The following is a description of a gene set: Human Gene Set: GOBP_INTRACILIARY_ANTEROGRADE_TRANSPORT studied in species Homo sapiens The directed movement of large protein complexes along microtubules from the cell body toward the tip of a cilium (also called flagellum), mediated by motor proteins., and this is the list of marker genes: CCDC38, IFT70B, IFT80, IFT27, IFT25, IFT81, CILK1, IFT20, IFT57, IFT122, IFT74, IFT52, IFT46, CLUAP1, IFT172, IFT56 (NCBI Gene Id 79989), IFT88, IFT22, TRAF3IP1